Given this list of marker genes Eef2k, Epha7, Pdgfa, Tesk1, Tom1l1, Mvp, Prlr, Ppp2ca, Mob1b, Nrg1, Grem1 (gremlin 1, DAN family BMP antagonist), Rap2b, Rap2c, Vegfc, Nek10, Chp1, Enpp1, Rad50, Gpnmb, Tnks1bp1, Pdgfb, Ddx3x, Nlrp12, Ppp2r5b, Ptprc, Ctnnd1, Ppp2r5d, Mre11a, Cav1, Gfra2, Vegfa, Errfi1, Nbn, Adipoq, Rassf2, Rap2a (RAS related protein 2a), Jun, Iqgap1, Ngf, D1Pas1 (NCBI Gene Id 98517), here is a description of the gene set: studied in species Mus musculus Any process that modulates the frequency, rate or extent of addition of the phosphorylation by a protein of one or more of its own residues. Mouse Gene Set: GOBP_REGULATION_OF_PROTEIN_AUTOPHOSPHORYLATION